The following is a description of a gene set: The receptor clustering process in which gamma-aminobutyric acid (GABA) receptors are localized to distinct domains in the cell membrane. species: Mus musculus Mouse Gene Set: GOBP_GAMMA_AMINOBUTYRIC_ACID_RECEPTOR_CLUSTERING, and this is the list of marker genes: Nrxn1, Shisa7, Lhfpl4, Gphn, Glrb